The following is a description of a gene set: The process of creating a trabecula in the bone. A trabecula is a tissue element in the form of a small beam, strut or rod. species: Homo sapiens Human Gene Set: GOBP_BONE_TRABECULA_FORMATION, and this is the list of marker genes: THBS3, WNT10B, SFRP1, CHAD, GREM1, FBN2 (fibrillin 2), MMP2, VEGFA, MSX2, COL1A1